The following is a description of a gene set: Human Gene Set: GOBP_RAB_PROTEIN_SIGNAL_TRANSDUCTION studied in species Homo sapiens An intracellular signaling cassette in which a small monomeric GTPase of the Rab subfamily relays a signal., and this is the list of marker genes: RAB39A, RAB21, CD2AP, GDI1, RAB9B, DENND3, DENND4A, RAB33A, DENND1A, RAB35, RAB4A, RAB33B, SGSM3, DENND4B, RAB39B, RAB4B, RAB12, RAB30, RAB15, RAB9A, MADD, MICALL2, DENND4C